The following is a description of a gene set: studied in species Mus musculus electronically inferred by orthology from the curated human pathway part of: Signaling by ERBB2 This event has been computationally inferred from an event that has been demonstrated in another species.<p>The inference is based on the homology mapping from PANTHER. Briefly, reactions for which all involved PhysicalEntities (in input, output and catalyst) have a mapped orthologue/paralogue (for complexes at least 75% of components must have a mapping) are inferred to the other species. Reactome Pathway: ERBB2 Regulates Cell Motility, and this is the list of marker genes: Egfr, Btc, Erbb2, Memo1, Erbb4 (erb-b2 receptor tyrosine kinase 4), Nrg3